Given this list of marker genes Smad3, Tgfb1, Runx3, Smad4 (SMAD family member 4), Trp53, Zfhx3, here is a description of the gene set: studied in species Mus musculus RUNX3 regulates CDKN1A transcription Mouse Gene Set: REACTOME_RUNX3_REGULATES_CDKN1A_TRANSCRIPTION